Given this list of marker genes Ano4, Ano9, Ano6, Ano7, Ano3, here is a description of the gene set: Mouse Gene Set: GOBP_CALCIUM_ACTIVATED_GALACTOSYLCERAMIDE_SCRAMBLING The movement of a population of galactosylceramide molecules from one leaflet of the plasma membrane bilayer to the opposite leaflet as a result of a calcium stimulus. species: Mus musculus